The following is a description of a gene set: studied in species Homo sapiens Abnormal preoccupation Preoccupations refers to being absorbed in any particular thought, activity, or concern that captures the attention of the individual. It may have a positive or negative connotation. Human Gene Set: HP_ABNORMAL_PREOCCUPATION, and this is the list of marker genes: DCTN1 (dynactin subunit 1), CACNA1H, TBX1, GABRB3, TP53, CYP27A1, NR3C1, HMBS, ECM1, HTT, TBP, IMPA1, GABRG2, CHRNA4, TP63, ESS2, NECTIN1, FMO3, FIG4, MSX1, PLA2G6, BRAF, ATRX, DGCR8, CHRNA2, SNCA, CDH23, CHRNB2, TIMM8A, CABP4, SPTBN1, USP8, DCDC2, IRF6, USP48, TMEM67, DGCR2, KCNT1, CPOX, SLC2A3, DGCR6, SLC2A1, GABRA1 (gamma-aminobutyric acid type A receptor subunit alpha1), VPS13A, CRH, CEP85L, JRK, PRDM8, PPOX, DEPDC5